Given this list of marker genes ETFDH (NCBI Gene Id 2110), FBN1, RAP1B, TAOK1, EP300, MPLKIP, HSPA9, FGF5, GP1BB, CSPP1, SLC7A14, CHM, LZTR1, TGFB2, B3GALNT2, PSAT1, ATP5F1A, ARSG, IFNGR1 (interferon gamma receptor 1), CYP1B1, SPEN, TGM3, USP45, UBE4B, LRP5 (NCBI Gene Id 8058), ACADS, INPP5E, BFSP1, IL10, TMEM270, NR4A2, LIM2, MED27, MTAP, BBS1, RP1L1, ERCC5, CTC1, CPAMD8, CHD6, TMEM216, POLR3GL, ATP5F1D, NRCAM, ALG3, TGFBR1, PTH1R, COL9A1, HDAC8, AIPL1, MT-ND6, CTNNB1, TUBG1, AGBL5, CA4 (carbonic anhydrase 4), CLPB, CHSY1, FANCC, AFF4, RTEL1, B9D2, VPS4A, B4GAT1, SDCCAG8, TAP1, MT-CYB, ALX3, VCP (NCBI Gene Id 94731), LIPH (NCBI Gene Id 619396), CYSLTR2, NAA10, FKRP, PDE6A, PTPN22, OCRL, PIK3R1, TRIM44 (NCBI Gene Id 54765), TRAPPC11, ATPAF2, POLG2, PNPLA6, CPT2, TCTN1, SUFU, CRPPA, AGA, PEX3, EOGT, PRKCZ, MED25 (NCBI Gene Id 81857, mediator complex subunit 25), RPL5, KIZ, SDHC, COL4A1, CFAP410, ZNF513, PRKAG2, PCYT1A, USF3, RPS24, SLC40A1, LAMB2, RREB1, PSMC3, NEK9, ARCN1, NCF1, SC5D, SPATA7, B3GALT6, PDE6B, CFAP418, IFT27, SETD2, XYLT2, NEU1, ETFA, PEX16, BFSP2, PNPT1, BUB1, BMP4, KRT74, RPS28, BAZ1B, PITX3, ADNP, RIC1, LETM1, LEMD2, AKT1, PDPN, LRP4, IFT80, HEATR3, AP1S1, MAN2B1, METTL27, SMAD4, RPS19 (ribosomal protein S19), IFT74, ABCA4, MFRP, NDUFB11, MIPEP, GCNT2, RD3, FIBP, ADAMTS10, APOA1, JMJD1C, TUBB3, PLCG2, RAD51, SAG, MT-TC (NCBI Gene Id 4511), POMGNT2, USH1G, TMEM107, TKT, TUB, LCA5, PLOD3, AMMECR1, PRG4, RDH11, ERCC3, ERCC2, HYCC1, CENPF, ATP5MK, RPS17, HSPG2, XPC, TUBGCP6, RAB3GAP2, PTCH2 (NCBI Gene Id 8643), LIMK1 (NCBI Gene Id 3984), COL18A1, IMPG2 (NCBI Gene Id 51443), ABCD1, HCCS, CEP164, PCDH15, ERCC8, HMBS, ADAMTSL4, MSMO1, TMEM231, PMM2, PALB2, DNMBP, MAB21L2, BCAP31, GJA5, KLHL7 (NCBI Gene Id 55975), ZNF408, PAK2, FZD4, ACTB, FGF3, GALM, CRYGB, PEX1, COL4A6, WDR81, FOSL2, FLNA, SLC4A4, GBA2, MOCS1, FAM111B, KIF21A, MT-TQ, AMACR, IDH3A, TONSL, BCOR, CCDC28B, MERTK, TKFC (triokinase and FMN cyclase), XRCC2, RPL31, EHMT1, WRAP53, COL25A1, RRM2B, ZNF526 (zinc finger protein 526), CNBP, OPA1, NDP, LIG3, CLN3, CRYBA2, MED11, SBF2, DNA2, VHL, FYCO1, TMTC3, MITF, MAPKAPK5, CNGB1, MYMK, POLR1C, SALL4, WRN, TBC1D20, PEX19, C4A, TLR4, COL11A1, PRPF6, APC2, FANCG, MAP2K2, CRYGD, TMEM127, DHCR7, MT-CO2, C12orf57, DHDDS, MYSM1, SPTBN1, ZEB2, RGR, CD247, SLC16A12, GNAQ, IDH3B, COMT, RFC2, ATP6V1A, FBN2, RPS27, ANAPC1, SEC24C, PRPH2 (peripherin 2), ABCA2, YAP1, AMER1, SLF2, TOPORS, RPL27, MVK, BBS4, COL7A1, PAX2, NEK2, ATP8A2, PRIM1, POMT2, CEP57, LUZP1, RPS29 (NCBI Gene Id 6235), CREBBP (NCBI Gene Id 1387), RPS6KA3, RHOA, SLX4, AIRE, COL4A4, ARPC4, NOTCH2, AGK, ALDH6A1, DMPK, EFEMP1, LOXL1, PIGY, TULP1, MRPS28, KCNH1, ERCC1, RSPO2, PARN, ROM1, PITX2, KLLN, IARS2, POLR1A, GALT, TXNDC15, CRB1, TAF6, TSR2, VIM, IL2RB (interleukin 2 receptor subunit beta), NIPBL, RALGAPA1, GMPPB, PROM1, WDR35, TCTN2, RP9, BDNF, GTF2E2, SIX6, NPM1, WHRN, COL9A2, NSD1, CNGA1, DBR1, ATP7B, SEC23B, COL4A5, CA8, ZFX, NAA60, TFAP2A (NCBI Gene Id 95131), COL2A1, CIB2, RERE, SOX2, PRDM16, ADA2, MAK (NCBI Gene Id 4117), RPL11, PRPF31, UBE2A, FLI1, OAT, RPS26, ALG8, POLG, KANSL1, GNA11, DNAJC30 (DnaJ heat shock protein family (Hsp40) member C30), KLRC4, AARS1, GABRD, BCKDK, MOCS2, INPP5K, HMX1, EYS, SALL2, RP2, KCTD1, COG4, PYCR1, NR2E3, PRCD, OPA3, ESCO2, BTNL2, ERCC6, AHI1, MT-TL1, CNGB3, TINF2, GNPAT, PTH, WDR73, INVS, RBM8A, ARL3, IL12A-AS1, NHS, PORCN, TBX4, MT-TK, BBS7, RLBP1, RRAGC, POMT1, DAG1, USH2A, CERKL, SF3B1 (NCBI Gene Id 23451), GALK1, AHR, CLIP2, TUBB2B, TBCK, MORC2, RAD51C, FKBP6, TRPM3, RPL8, LRP2, NMNAT1, SPRTN, FANCD2, MINPP1, OTX2, KDSR, FANCL, B9D1, HS2ST1, PTPN2, SMC5, FDXR, RB1, EIF4H, PEX5, PDE6G, PTEN, RPE65, NSUN2, B4GALNT1, POMK, CRYAB, RPL18, LAS1L, TYMS, TSPAN12, RET, AASS, RPS10, TBX1, REEP6, JAM3, PDZD7, SPRED1, SDHB, DYRK1A, BEST1, SMPX, KCNJ13, CYP7B1, TUBA1A (NCBI Gene Id 95407), PEX10, COQ6, EPHA2, STX1A, GATA1, GTF2IRD2 (GTF2I repeat domain containing 2), BAP1, RPS20, P3H2, SEC23A, RPL35A, GUCY2D, RPL26, USH1C, UFD1, TERC, MBTPS1, DLL4, INTS1, POLR1D, ALMS1, FANCF, ZBTB20, MAFA, LMNA, COX7B, PIK3C2A, RNF113A, FSCN2, IL23R, TTC8, TELO2, MAF, ITM2B, CYP27A1, RPL9, FOXE3, USB1, ATOH7, HNRNPDL, FIG4, PRPF3, UBAC2, GJA3, FBXL4, RXYLT1, BBS10, ATAD3A, SCLT1, SHROOM4 (NCBI Gene Id 57477), B3GLCT, TGFBI, ALG2, KRT86, DYNC2I1, GTF2IRD1, FOXC2, HLA-B, GUCA1B, GEMIN4, HTRA2, FOXC1, FAM50A, LSS, SPTLC1, GJB3, NUP188, HNRNPA1, SUOX, BRCA2, IFT140, JAG1, SLC25A13, GALE, BLTP1, ARL2BP, IQCB1, COL4A3, LRAT, ARL6, ESPN, KRT71, NF2, RPGRIP1L, MAX, DDB2, SMARCB1, EIF2B2, NOP10, BRCC3, NPHP3, ELN, TRIP13, LONP1, TRAF3IP1, TBL2, CBS, PTCH1, GJA1, PHGDH, DSG4, CASZ1, MT-ND1, CHRDL1 (chordin like 1), DNMT1, FANCE, VLDLR, ITPA, COL5A1, FAM161A, IFT88, PHYH, WNT3, ASPH, CC2D2A, DKC1, CEP19, SEC31A, SCAPER, IFT172, GSN, ZNF335, CRYBB3, SIPA1L3, POLR1B, HARS1, LZTFL1, ARHGEF18, PHOX2A, SUMF1, BUB1B, SLC2A1, VPS37D, ARVCF (NCBI Gene Id 421), HGSNAT, SMC3, RPL15, KRT83, WDR19, CAV1, CDHR1, RDH12, BBS9, HLA-DRB1, SDHD, MT-ATP6, MEFV, TGFBR2, PEX2, FAS, PRPF4, PCARE, ABCA12, FANCM, PEX7, BBS12, RECQL4, FANCI, GNAS, RP1, BRCA1, SMG8, ANO1, FAR1, RPL35, IMPG1, CRX, MT-ND5, SIN3A, DHX38, CDH11, MKKS, IL2RA, DYNC2I2, IMPDH1, MT-CO3, BBS2, GJB6, SLC25A4, TMEM70, DYNC2H1, COPB1, ABHD5, BRD4, CRYBB2, SMAD3, PQBP1, RPGR, PRUNE1, MYH9 (NCBI Gene Id 65212), ATP11A, TARS1, HSF4, RDH5, SALL1, LAMB1, SKI, FBXW11, TRIM32, EPCAM, MMP23B, PIK3CA, WT1, POLR3A, CLRN1, OCLN, GTF2I, DGUOK, EPG5, SRD5A3, PRPF8, IDH1, CHMP4B, ENTPD1, LARGE1, STAT4 (signal transducer and activator of transcription 4), CRYAA, MT-TS2, ARHGAP31, TBC1D24, ALDOB, SMC1A, ATP6V1B2, ADAMTS17, HLA-A, FH, RNF13, ETFB, TERT, PAH, GTF2H5, RAB18, FANCA, SLC33A1, FLVCR1, LOXL3, WFS1, CCR1, FANCB, BRIP1, RNH1, CEP78, FBLN5, UBE2T, DNM1L, MYO7A, ADGRV1, RBPJ, MIP, NHP2, PAX6, COL9A3, ATP5F1E, MT-ATP8, PEX12, ANO10, KRT81, CRYBA4, TWNK, GDF6, WDPCP, TCOF1, ARSL, UBA5, GLA, MECP2, IL12A, TMEM237, NPHP1, CTDP1, NAGA, XRCC4, ADAMTS18, GSR, VCAN, PEX6, TUBB4B, COL11A2, CHD7, LTBP2, NAXD, RPS7, MT-TV, RTN4IP1, TMEM67, MIR184, TBR1, PERCC1 (proline and glutamate rich with coiled coil 1), NRL (neural retina leucine zipper), FZD5, CRYBB1, HIRA, DACT1, FAM111A, PANK4, MT-TW (NCBI Gene Id 4578), POMGNT1 (protein O-linked mannose N-acetylglucosaminyltransferase 1 (beta 1,2-)), MAD2L2, TDRD7, SREBF1, NOD2, CARS1, RPS15A, GJA8, DOCK6, SNRNP200 (NCBI Gene Id 692221), OFD1, NOTCH1, SMCHD1, BBS5, TRPV4, HNRNPA2B1, PEX11B, VSX2, GJB4, PXDN, RAD21, FLNB, BCS1L, VAC14, BBIP1, IKBKG, RPGRIP1, LMX1B, EBP, RFWD3, FTL, RBP3, FKTN, SIL1, STX16, KCNN3, ALDH18A1, MKS1, DPAGT1, SNUPN, ANKRD55, CRYBA1, PRR12, ABHD12, NPHP4, PEX13, RAB3GAP1, SEMA4A (semaphorin 4A), KCNAB2, KCNA4, LMBRD2, ARL2, PHF6, BUB3, BUD23, MT-CO1, TCTN3, CEP290, PEX26 (NCBI Gene Id 55670), LPAR6, GFER (growth factor, augmenter of liver regeneration), BRF1, KRT25, MT-TF, EED, CRYGC, PEX14, MIR204, XPA, PLK4, APC, UNC45B, ALX1, RHO, ERAP1, GTPBP2, USP9X, KIAA1549, LIG4, CDH23, ERCC4, KMT2C (lysine methyltransferase 2C), ELP4, NACC1, CRYGS, KIF11, here is a description of the gene set: species: Homo sapiens Abnormal lens morphology Human Gene Set: HP_ABNORMAL_LENS_MORPHOLOGY An abnormality of the lens.